The following is a description of a gene set: The chemical reactions and pathways resulting in the formation of aminoglycans, any polymer containing amino groups that consists of more than about 10 monosaccharide residues joined to each other by glycosidic linkages. species: Homo sapiens Human Gene Set: GOBP_AMINOGLYCAN_BIOSYNTHETIC_PROCESS, and this is the list of marker genes: ABCC5, IL1B, B3GALT6, B3GNT9, HS3ST3B1, TGFB1, CHST3, CHSY3, CHPF, HAS3, B3GNT3, CLTC, B3GNT8, HEXA, EXT2, AP2A1, CHSY1, CHST11, CEMIP, HS3ST1, CHST13, GCNT2, B3GNT6, IGF1, CHST12, B3GAT3, HAS2, B4GALT7, EGF, HAS1, GALNT5, SLC35B2, EXT1, B4GALT5, B3GAT1, XYLT2, HS3ST2, PXYLP1, CHST7, CSGALNACT2 (chondroitin sulfate N-acetylgalactosaminyltransferase 2), SMPD3, PDGFB, B4GAT1, B3GNT7, NFKB1, B3GAT2, XYLT1 (xylosyltransferase 1), CHPF2, B3GNT4, B3GNT2, UGDH, CSGALNACT1, CYTL1, HS3ST3A1